Given this list of marker genes Jagn1, Csf3, Csf2ra, Ceacam1, Hax1, Hcls1, here is a description of the gene set: The series of molecular signals initiated by the binding of the cytokine granulocyte colony-stimulating factor (G-CSF) to its receptor on the surface of a target cell, and ending with the regulation of a downstream cellular process, e.g. transcription. G-CSF binds to the receptor (CSF3R). species: Mus musculus Mouse Gene Set: GOBP_GRANULOCYTE_COLONY_STIMULATING_FACTOR_SIGNALING_PATHWAY